The following is a description of a gene set: Enables the transfer of a solute or solutes from one side of a membrane to the other according to the reaction: amino acid(out) + cation(out) = amino acid(in) + cation(in). Mouse Gene Set: GOMF_AMINO_ACID_MONOATOMIC_CATION_SYMPORTER_ACTIVITY studied in species Mus musculus, and this is the list of marker genes: Slc6a20b, Slc38a2, Slc6a12 (NCBI Gene Id 14411), Slc6a1, Slc1a7, Slc6a11, Slc1a6, Slc38a3, Slc6a15, Slc6a9, Slc1a3, Slc25a22, Slc6a13, Slc6a20a, Slc6a6, Slc38a7, Slc6a14, Slc6a7, Slc38a4, Slc38a1, Slc36a1, Slc1a2, Slc6a5, Slc1a1, Slc36a3, Slc25a18, Slc6a8, Slc6a18, Slc36a2